Given this list of marker genes Gk, Lipf, Plpp2, Mogat2, Lpl, Agpat1, Agpat2, Gk2, Agpat4, Plpp1 (NCBI Gene Id 19012), Lipc, Gnpat, Dgat1, Agps, Pnpla2, Gpam, Agpat3, Lipe, Dgat2, Agpat5, Gpd1, Mogat1, Plpp3, here is a description of the gene set: Triacylglyceride synthesis studied in species Mus musculus Mouse Gene Set: WP_TRIACYLGLYCERIDE_SYNTHESIS